The following is a description of a gene set: Formation of a lamellipodium, a thin sheetlike extension of the surface of a migrating cell. Human Gene Set: GOBP_LAMELLIPODIUM_ASSEMBLY species: Homo sapiens, and this is the list of marker genes: CAPZB, ABLIM3, PIK3CA, CDC42, PTPRO, KIT, NCKAP1, TWF2, EPHA2, FRMD7, AJUBA, PARVB, FER, CCDC88A, WASF2, ACTR2, P2RY12, FSCN1, TWF1, RAC2, S1PR1, AUTS2, CLRN1, ITGB1, ABI2, AVIL, DMTN (dematin actin binding protein), ARPC2, WAS, WASF3, MSTN, CYFIP1, ABLIM1, MIR196A1, CDH13, GOLPH3, AKIRIN1, HRG, OCLN, CARMIL2, HSP90AA1, PIK3R1, WNT1, CFL1, ARHGEF4, NUP85, ABLIM2, SPATA13, RAC1, VAV3, MIR214, SLIT2, CARMIL1, MTOR, NCK1 (NCBI Gene Id 4690), ACTR3, PLCE1, SH2B1, ARFIP2, SRGAP2, BIN3, PLXNB3, RHOD, VAV2, WHAMM, BRK1, NCK2, VCL, ARHGEF7, SPEF1, ABI3, ARHGEF6